Given this list of marker genes ALOX5AP, IFITM1, BAG3, CD69, CST7, CMC1, HSPD1, HSP90AA1, HSPA8, KLRK1, TRGC1, ITGAL, NKG7, DNAJA1, TXNIP, KLRD1, SYTL3, IFNG, HSPA1B, IKZF3, DUSP2, TXK, CD3E, PYHIN1, BTG2, DNAJA4, CD247, LCP1, CCL5, IL2RB, HSPH1, GNLY, GZMK, BTN3A1 (NCBI Gene Id 11119), EOMES (eomesodermin), GZMA, HSPA6, KLRB1, RAC2, IL2RG, DNAJB1, CD7, HSPA1A, KLRF1, CACYBP, PTPRC, RUNX3, STK17A, WIPF1, here is a description of the gene set: studied in species Homo sapiens Human Gene Set: AIZARANI_LIVER_C12_NK_NKT_CELLS_4 from publication Aizarani N, Saviano A, Sagar, Mailly L, Durand S, Herman JS, Pessaux P, Baumert TF, Grün D (PMID 31292543)